Given this list of marker genes H2AC4, H2BC21, H2AC20, ERCC3, H2AC6, H2AC7, POLR2K, POLR2E, CCNH, H4C1, H2AB1, ERCC2, H2BC4, H2BC5, H2BC14 (NCBI Gene Id 8342), GTF2H2, MNAT1, H2AX, POLR1E, H2BC9, TAF1B, POLR1D, POLR1F, H2BC11, POLR1C, CBX3, H2AJ, H3C15, H2BC26, H2BC1, H2BC12, POLR1B, POLR2L, POLR2F, H2AC14, POLR1G, POLR1A, CDK7, POLR2H, H2BC15, H3C1, H2BC12L, TAF1D (NCBI Gene Id 79101), TBP, H3-3A, GTF2H1, H2AZ2, POLR1H, RRN3, UBTF, GTF2H5, H2BC13, GTF2H4, H2BC3, TAF1C, GTF2H3, TAF1A, H2BC17, H2AC18, here is a description of the gene set: part of: RNA Polymerase I Promoter Clearance As the active RNA Polymerase I complex leaves the promoter Rrn3 dissociates from the complex. RNA polymerase I Promoter Clearance is complete and Chain Elongation begins. The assembly of the initiation complex on the promoter and the transition from a closed to an open complex is then followed by promoter clearance and transcription elongation by RNA Pol I. Unlike the RNA polymerase II system, RNA polymerase I transcription does not require a form of energy such as ATP for initiation and elongation. Regulatory mechanisms operating at both the level of transcription initiation and elongation probably concurrently to adjust the level of rRNA synthesis to the need of the cell. Reactome Pathway: RNA Polymerase I Promoter Escape species: Homo sapiens